The following is a description of a gene set: Genes up-regulated in blood 3d vs 0d in adults (21-51) after exposure to Influenza A (H1N1) 2009 Monovalent Vaccine (Sanofi Pasteur), time point 3D, administered i.m. Human Gene Set: GIAROLA_SILVA_BLOOD_INFLUENZA_A_AGE_21_51YO_3DY_UP from publication Giarola-Silva S, Coelho-Dos-Reis JGA, Mourão MM, Campi-Azevedo AC, Nakagaki Silva EE, Luiza-Silva M, Martins MA, Silveira-Cassette ACO, Batista MA, Peruhype-Magalhães V, Antonelli LRDV, Leite Ribeiro JG, Elói-Santos SM, Machado AV, Teixeira-Carvalho A, Martins-Filho OA, Araújo MSS (PMID 28549970) The study aimed at identifying biomarkers of immune response elicited by non-adjuvanted-(NAV) and adjuvanted-(AV) H1N1(pdm09) vaccines. The results showed that despite both vaccines elicited similar levels of anti-H1N1 antibodies at day30 after vaccination, higher reactivity was observed in AV at day180. While AV induced early changes in cell-surface molecules on monocytes, CD4<sup>+</sup>, CD8<sup>+</sup> T-cells and B-cells, NAV triggered minor changes, starting later on at day3. Furthermore, AV induced a late and persistent increase in TLR gene expression after day3, except for tlr4, while NAV displayed earlier but transient tlr3/4/7/9 up-regulation. Contrasting with NAV, prominent chemokine gene expression (cxcl8,cxcl9,ccl5) and a broad spectrum up-regulation of plasmatic biomarkers (CXCL8,IL-6,IL-1beta,IL-12,IL-10) was evident in AV, which showed a major involvement of TNF and IL-10. Similarly, AV induced a robust IL-10-modulated proinflammatory storm, with early and persistent involvement of TNF-alpha/IL-12/IFN-gamma axis derived from NK-cells, CD4<sup>+</sup> and CD8<sup>+</sup> T-cells along with promiscuous production of IL-4/IL-5/IL-13. Conversely, NAV promotes a concise and restricted intracytoplasmic chemokine/cytokine response, essentially mediated by TNF-alpha and IL-4, with late IL-10 production by CD8<sup>+</sup> T-cells. Systems biology approach underscored that AV guided the formation of an imbricate network characterized by a progressive increase in the number of neighborhood connections amongst innate and adaptive immunity. In AV, the early cross-talk between innate and adaptive immunity, followed by the triad NK/CD4<sup>+</sup>/CD8<sup>+</sup> T-cells at day3, sponsored a later/robust biomarker network. These findings indicate the relevance of adjuvanted vaccination to orchestrate broad, balanced and multifactorial cellular immune events that lead ultimately to a stronger H1N1 humoral immunity. species: Homo sapiens, and this is the list of marker genes: TLR4, TLR3, TLR7, IFNG, TLR9